The following is a description of a gene set: Mouse Gene Set: GOBP_GLYCEROLIPID_METABOLIC_PROCESS The chemical reactions and pathways involving glycerolipids, any lipid with a glycerol backbone. Diacylglycerol and phosphatidate are key lipid intermediates of glycerolipid biosynthesis. species: Mus musculus, and this is the list of marker genes: Pik3r5, Nkx2-3, Pik3ca, Sik1, Cps1, Serac1, Ctdnep1, Pla2g4a, Pigyl, Pcyt2, Pik3r1, Dpm3, Dgkh, Pdgfa, Ptpmt1, Pip4p1, Dbi, Far1, Crls1, Ocrl, Pla2g4f, Ldlr, Pgap4, Pigt, Pla2g3, Plcb1, Lypla2, Plb1, Synj2, Abhd5, Hadha, Pip5kl1, Pnpla6, Pip5k1c, Tamm41, Tmx1 (NCBI Gene Id 72736), Apoh, Spata18, Sel1l, Lpcat2b (NCBI Gene Id 70902), Lpgat1, Ajuba, Pi4ka, Dgkk, Gal3st1, Pi4k2a, Pla2g2c, Pigv, Acsl4, Pnliprp2, Lpcat1 (lysophosphatidylcholine acyltransferase 1), Cept1, Apof, Insig1, Pon1, Htr2a, Mir423, Pgap3, Htr2c, Mogat1, Pnpla5, Lclat1, Pla2g4e, Pdgfrb, Serinc2, Lpin2, Apoa4, Dpm2, Plcb2 (phospholipase C, beta 2), Serinc5, Agpat2, Phb2 (prohibitin 2), Dgkd, Agk, Abhd8, Dgki, Gpcpd1, Pigw, Gk2, Sh3yl1, Inpp5j, Plcb3, Lcat, Pld2, C3, Pla2g2e, Ddhd1, Pnpla8, Dhrs7b, Plaat1, Selenoi, Slc22a4, Plce1, Prdx6 (NCBI Gene Id 320807), Pla2g4c, Pank2, Gk5, Pigc, Abca3, Pigl, Ipmk, Ang6, Fgf7, Galr2, Dgkg, Thrsp, Apoa2, Ang4, Inpp5d, Pigx, Gk, Lpin3, Cav1, Pla2g6, Scarb1, Pigb, Lpcat3, Pik3r4 (NCBI Gene Id 97556), Plaat3, Mecp2, Plcl1, Faah, Ang5, Mtmr1, Lipe (lipase, hormone sensitive), Pigg, Pigp, Apoa1, Htr2b, Il6st, Chpt1, Pigq, Naaa, Pigu, Ces1d, Pitpnc1, Nr1h2, Pigo, Pi4k2b, Abhd2, Inppl1, Pten, Abhd16a, Oc90, Pip4k2b, Mtm1, Gpihbp1, Pcsk9, Dnajc19, Plcg2, Daglb, Tafazzin, Prdx6b, Gdpd3, Nr1h4, Gnpat (NCBI Gene Id 51942), Alox15, Ip6k1, Pla2g1b, Pnliprp1, Pik3c2b, Gpr82, Dpm1, Pgap1, Mtmr3, Mtmr7, Smg1, Cnep1r1, Scd1, Ang, Cat, Kat5, Serpina12, Apobec1, Gpd1, Vac14, Mboat7, Inpp5b, Mboat1, Lipg, Pld1, Fabp5, Abhd16b, Inpp1, Rbp2, Plscr3, Apoc2, Thrb (thyroid hormone receptor beta), Cav3, Mtmr6, Sorl1, Inpp5k, Cpt1a (NCBI Gene Id 225890), Etnk1, Apoc2l, Them5, Pnpla2, Ttc7b, Pigs, Slc27a5, Sirt1, Bpnt2, Efr3b, Agpat5, Atm, Becn1, Gdpd1, Cln3, Dgat1, G6pc1, Pla2g10, Dgka, Pi4kb, Pign, Pik3c3, Mogat2, Awat2, Angptl3, Blvra, Pik3cg, Pcyt1a, Impa1 (inositol (myo)-1(or 4)-monophosphatase 1), Cidec, Gpat4, Capn2, Plcd1, Inpp4b, Gpld1, Gykl1, Agpat4, Ces1g, Gpat2, Cdipt, Apoc1 (apolipoprotein C-I), Lipc, Ptpn11, Pip5k1a, Pisd, Hycc2, Gnb3, Ptdss2, Chkb, Srebf1, Piga, Acp6, Pla2g2d, Hycc1, Fabp3, Abhd12, Mtmr10, Tbl1xr1, Enpp2 (ectonucleotide pyrophosphatase/phosphodiesterase 2), Plaat5, Serinc1, Uvrag, Dgkz (diacylglycerol kinase zeta), Abhd6, Agpat1, Tnfaip8l3, Ip6k3, Ddhd2, Fgf21, Gpx1 (glutathione peroxidase 1), Acsl3, Fitm2, Tmem68, Cideb, Abhd12b, Lmf1, Slc27a1, Fig4, Pigf, Inpp5e, Mttp, Dgke, Apob, Plek, Dagla, Atg14, Pemt, Pik3c2a, Tmem150a, Lpin1, Cwh43, Tcf7l2, Pikfyve, Plch1, Chka, Pla2g4b, Dgat2l6, Napepld, Synj1, Mfsd2a, Acsl5, Pla2g2a, Dgkq, Slc37a4, Mtmr9, Pik3c2g, Agmo, Gpam, Mtmr4, Dgat2, Pgap2, Pnpla1, Tnxb, Plcg1 (phospholipase C, gamma 1), Pdgfb, Pck2, Apobr, Etnk2, Pigm, Plcb4 (NCBI Gene Id 99123), Gpat3, Mgll, Inpp5a, Ptdss1, Agap2, Ang2, Cdk8, Cyp2e1, Pyurf, Smpd4, Pigz, Inpp5f, Impa2, Pla2g15, Ttc7, Lpl, Pik3cd, Ptprq, Rgn, Plcd4, Avil, Pgp, Plin5, Esr1, Pnpla3, Mtmr12, Pck1, Itpka, Pla2g7, Aadac, Apoc3, Acsl6, Pgs1, Pip4p2, Gpaa1, Bscl2, Rab38, Mppe1, Inpp4a, Pla2g5, Mtmr2, Plscr1, Hdhd5, Mtmr11, Apoa5, Insig2, Sh3glb1, Pla2g4d, Ccnc, Slc30a5, Abhd4, Plcl2 (NCBI Gene Id 29868), Bpnt1, Pigh, Lpcat4, Nr1h3, Lpcat2, Pik3cb, Itpkc, Cds2, Lrat, Agpat3, Pcyt1b, Pip4k2c, Pip5k1b, Acsl1, Pla2g2f, Plch2, Lipa, Mboat2, Apoe, Pip4k2a, Pigk, Cds1, Dgkb, Sacm1l, Itpkb, Ip6k2, Abhd3, Plpp1, Pnpla7, Pnlip, Chrm5